The following is a description of a gene set: Mouse Gene Set: GOCC_CILIARY_BASAL_BODY species: Mus musculus A membrane-tethered, short cylindrical array of microtubules and associated proteins found at the base of a eukaryotic cilium (also called flagellum) that is similar in structure to a centriole and derives from it. The cilium basal body is the site of assembly and remodeling of the cilium and serves as a nucleation site for axoneme growth. As well as anchoring the cilium, it is thought to provide a selective gateway regulating the entry of ciliary proteins and vesicles by intraflagellar transport., and this is the list of marker genes: Ift80, Cfap298, Smad6, Dync2i2, Ptk2, Arl2bp, Arhgap35, Ssx2ip, Poc1a, Cdk5rap2, Cdkl5, Tcea2, Gabarapl1, Pdzd7, Cdkn1b, Dync2li1, Traf3ip1, Cep20, Ffar4, Pkhd1, Rab6a, Topors, Atp2b4 (NCBI Gene Id 381290), C2cd3, Rpgr, Tbc1d31, Nfe2l2, Lca5, Ush1g, Sting1, Cimip2a (NCBI Gene Id 68222), Bbs1 (NCBI Gene Id 52028), Atf3, Dzip1l, Arl13b (NCBI Gene Id 77950), Rabep2, Gnai2, Ctnnb1, Cibar2, Kif11, B9d2, Cfap126, Bub1b, Tulp3, Mkks, Fank1, Cep290, Cfap70, Katnip, Ofd1, Sdccag8, Fbf1, Rab8a, Cc2d1a, Rab11fip3, Pcm1, Prkcz, Tubgcp5, Cetn4, Bbs5, Rilpl1, Cep350, Nup85, Ttll7, Cimap3, Cdc45, Ift88, Cep19, Kif17, Cfap20, Pola2, Dzip1, Cby1, Mapk15, Ruvbl2, Prpf6, Crocc, Ccdc88a, Utrn, Braf, Tbc1d7, Saxo1, Agbl2, Intu, Mark4, Cfap206 (cilia and flagella associated protein 206), Cilk1, Cep68, Gas8, Cep44, Irs1, Cfap100, Cep131, Chrm2, Rp2, Ift81, Akap9, Gnai1, Tuba3a, Cep250, Cdk10, Ccsap, Psmb4, Ush2a, Adcy9, Creb1, Pkd2, Ssna1, Fzd6, Nin, Ttll5, Ift122, 1700012B09Rik, Cep162, Zfp330, Hipk1, Ttbk2, Enkd1, Dctn1, Pik3r4, Lrrc45, Kmt5b, Ttll6, Ttll4, Akt1, Cep78, Rrm1, Cplane2, Nphp4, Cyld, Akt3, Mapk3, Cadps2, Ccdc61, Cfap157, Camsap3, Cdc14a, Ift20, Cep152, Mks1, Mns1, Cspp1, Rttn, Ruvbl1, Ccdc14, Bcl3, Kifap3, Dync2i1, Efhc2, Ttll11, Fam161a, Bbs7, Ift140, Wdr11, Iqcd (NCBI Gene Id 75732), Ccdc178, Cenpj, Togaram1, Smad7, Rpap3, Ttll13, Dis3l, Nme7 (NCBI Gene Id 338485), Ptpn23, Ccdc66, Ttll9, Erc1, Prkca (protein kinase C, alpha), Nek4, Evc, Tsc1, Mlf1, Ccdc96, Egfr, Cep128, Ezr, Odf2l, Ttll2, Agtpbp1, Nedd9, Agbl4, Nek2, Ccdc81, Spag5, Arl2, Smad3, Hras, Prkaa2, Rab28, Sema4d, Alms1, Rpgrip1l, Armc9 (armadillo repeat containing 9), Atxn10, Gas2l2, Cep170, Odad3, Rilp, Nme3, Map2k1, Nedd1, Psen2, Abcc3, Cenpf, Luzp1, Smg6, Pcnt, Fbxw8, Sclt1, Odf2, Ccdc65, Ckap2, Tubg1, Mapkapk2, Rabl2, Cep41, Kif20b, Kif7, Marchf7, Pqbp1, Disc1, B9d1, Camsap2, Aurka, Rabl6 (RAB, member RAS oncogene family-like 6), Ttll1, Mak, Hdac6, Kncn, Wdr35, Lrrk2, Gnai3, Bbs9, Saxo2, Mapk1, Cetn3, Cep89, Ppp4r4, Dnaaf2, Mapre1, Daam1, Wrap73, Cys1, Bbs4, Bbs2, Tbc1d30, Ttc8, Ahi1, Spata7, Cfap144, Cfap410, Prkaa1, Jade1, Cfap90, Ift56, Ift70b, Mme, Cntrob, Dlg5, Vcp, Ift57, Haus7, Ift43, Acaa2, Ccdc113, Bbof1, Rab6b, Mical1, Bag3, Arl3, Spaca9 (sperm acrosome associated 9), Cep72, Haus3, Ocrl, Spice1, Psmc4 (proteasome (prosome, macropain) 26S subunit, ATPase, 4), Cibar1, Axdnd1, Whrn, Entr1, Gli1, Psme3, Poc1b (NCBI Gene Id 71261), Csnk1a1, Gli2, Cntrl, S100b, Ift52, Adrb2, Tubgcp2, Rilpl2, Ift172, 2700049A03Rik, Cetn2, Smad4, Daw1, Tapt1, Gle1